The following is a description of a gene set: studied in species Mus musculus Mouse Gene Set: GOBP_DETECTION_OF_EXTERNAL_STIMULUS The series of events in which an external stimulus is received by a cell and converted into a molecular signal., and this is the list of marker genes: Scn9a, Rest, Ano3, Pawr, Scrn3 (NCBI Gene Id 99245), Nrg1, Cav3, Pkd1, Guca1a, Gnat2, Cxcr4, Ptprq, Opn1mw, Rrh, Pde6d, Tmem120a, Il18, Pdzd7, Rho, Lrit1, Lxn, Pkd2, Nox3, Aipl1, Cacnb3, Jup, Serpine2, Whrn, Tac4, Arrb2, Tmem87a, Lhfpl5, Pkdrej, Guca1b, Chrna9, Foxf1, Crb1, Cep250 (NCBI Gene Id 99368), Tmc1, Strc, Trpv1, Rpe65, Pkd2l2, Rom1, Tcap, Cacna2d4, Otop1, Slc24a4, Opn5, Mmp24, Tmc2, Htr7, Pkd2l1, Pkd1l3, Tlr4, Adgrv1, Kcnk4, Calca, Ephb1, Grin2b, Sox2, Prdm12, Rbp4, Pde6b, Trpa1, Adora1, Pde6c, Nr2f6, Grin2a, Prph2, Disc1, Cabp4 (NCBI Gene Id 73660), Piezo1, Grk1, Ntsr1, Scn11a (sodium channel, voltage-gated, type XI, alpha), Ttr, Htr2a, Best1, Comt, Bace1, Csrp3, Gja10, Ccdc66, Fyn, Sema5a, Col11a1, Fech, Ntrk1, Grm6, Tac1, Slc12a2, Gucy2f, Reep6, Gnb1, Rgs9bp, Scn1a, Opn1sw, Grm8, Igf1, Itga2, Rgr, Atp8a2, Pkd1l1, Asic2, Irx6, Ttn, Cngb1, Cacna1f, Pnpla2, Scn10a, Kcnk2, Grik2, Myc, Gngt1, Ngfr, Drgx, Phf24, Opn3, Chrna5, Arrb1, Cds2, Pcdh15, Piezo2 (piezo-type mechanosensitive ion channel component 2), Pjvk, Pcare, Tnf, Gpr88, Kit (NCBI Gene Id 16590), Ano1, Kcnq1, Gnat1, Sema5b, Opn4, Rcvrn, Cxcl12, Pcp2, Pkd1l2, Hpn, Kcna1, Cacnb4, Gpr52, Chrna10, Mkks, Gnat3, Wdr47, Tulp1, Grin2d, Atp2b2, Asic3